The following is a description of a gene set: Abnormal T cell morphology Human Gene Set: HP_ABNORMAL_T_CELL_MORPHOLOGY Abnormal increase or decrease of total or subset T cell count. T cells are commonly characterized as CD3+ lymphocytes, or their subpopulations, in the blood, compared to a reference range for a given sex and age-group, measured ex vivo. These may include both TCR alpha/beta and gamma/delta T cells. species: Homo sapiens, and this is the list of marker genes: LAT, LCK, SYK, CIITA (NCBI Gene Id 4261), DEF6 (DEF6 guanine nucleotide exchange factor), NBN, BCL11B, CD3D, IRAK4, RASGRP1, CD79A, MS4A1, RAG2, IKBKB, CASP8, ATM (ATM serine/threonine kinase), LEPR, RIPK1, OTULIN (OTU deubiquitinase with linear linkage specificity), TNFRSF13B, POLD1 (NCBI Gene Id 5424), HLA-DRB1, POMP, RAG1, CBLB, IL7R, RPA1, EXTL3, LYN, BTNL2, BCL10, IL2RB, SH2D1A, NHEJ1, CD28, CD247, KDM6A, KMT2D, SP110, FASLG, PNP, CD3G, MAP3K14, CARD11, TNFRSF13C, IRF1 (NCBI Gene Id 96501), IL21, SASH3, ITK (NCBI Gene Id 3702), CD3E, MYD88, LCP2, CD81, TCF3 (transcription factor 3), CD79B, CTLA4, CARD9, PGM3, IL2RG, NFKBIA, RNF31 (NCBI Gene Id 80191), ADA, ACP5, WAS, PSMB10, FOXN1, PIK3CG, ICOS, POLD3, RAC2, CD8A, PRKDC, EPG5, DOCK2, XIAP, WDR1, BLNK, KNSTRN, CD4, FAS, IGLL1, DCLRE1C (DNA cross-link repair 1C), MCM10, RHOH, MYC, GATA2, RFXAP, DOCK8, HLA-DPB1, BLM, STAT1, PIK3CD, IL2RA, NCKAP1L, RFXANK, WIPF1, SMARCAL1, PIK3R1, CD19, SEC61A1, ZAP70, FOXP3, CR2, FCHO1, MAGT1, TNFRSF1B, IL7 (interleukin 7), NSMCE3, PSMB9, PTPRC, AP3B1, JAK3, STN1 (STN1 subunit of CST complex), DNMT3B, BTK, DIAPH1, ATP6AP2, TBX2, UNC119 (NCBI Gene Id 9094), CTNNBL1, TOM1, LIG1, IKBKG, RFX5, IVNS1ABP, LEP, CTPS1, CASP10